Given this list of marker genes Tcf3, Psma3, Psmc4, Ubb, Psmd6, Gata1, Gata3, Psmb6, Tal1, Psma2, Psmc6, Trp73, Psma6, Cbfb, Psmd7, Ldb1, Psmb5, Psmd13, Psmd1, Psmb4, Lmo2, Psmc3, Psma5, Psma1, Rps27a, Ccnh, Psmc1, Gata2, Psmb7, Yap1, Psmc2 (proteasome (prosome, macropain) 26S subunit, ATPase 2), Psma4, Psmc5, Psma7, Psmd12, here is a description of the gene set: This event has been computationally inferred from an event that has been demonstrated in another species.<p>The inference is based on the homology mapping from PANTHER. Briefly, reactions for which all involved PhysicalEntities (in input, output and catalyst) have a mapped orthologue/paralogue (for complexes at least 75% of components must have a mapping) are inferred to the other species. part of: Transcriptional regulation by RUNX1 studied in species Mus musculus electronically inferred by orthology from the curated human pathway Reactome Pathway: RUNX1 regulates transcription of genes involved in differentiation of HSCs